Given this list of marker genes PLS1, CLDN11, KRTAP26-1, RPS16, THBS2, ARC, FMOD, COL9A1, TUBB2B, KRTAP24-1, TUBB6, CRYGS, MRPL43, KHDC3L, NEFH, COL4A4, H2AZ2, CTNNA1, RPL7, RPS3A, DPT, GPM6B, FBN3, TTN, KRTAP29-1, ENAM, LIM2, DCTN3, STATH, LMNTD2, RPS4Y1, HAPLN1 (hyaluronan and proteoglycan link protein 1, NCBI Gene Id 1404), H2AX (NCBI Gene Id 3014), H2AC18, LTBP4, ERBIN (NCBI Gene Id 55914), MACROH2A1, NUP160, SHANK1, COL8A1, FBLN1, H4C11, KRT222, H2BC9, HSPB2, RPS6, RPS7, THBS3, H2AC15, H1-2, RPLP1, COL4A1, CLDN19, ESM1, KRT16, DCN, AMELY, TUBB8B, LAMA1, H1-3, SEH1L, SEC13, RPS28, EPB41, CRYGC, RPL11, MRPS21, KRT17, NPNT, RPL7A, NUP155, H3C1, H3C8, TNC, RPL10L, EPB41L3 (erythrocyte membrane protein band 4.1 like 3), CRYGD, COL1A1, POTEE, KRT28, RPS3, H4C4, KRT79, KRT24, SEPTIN4, SMTN, MRPL20, SEC31B, BICD1, PXDN, EPB42, ELN, KRTAP25-1, CLTA, THBS1, COL6A5, OGN (NCBI Gene Id 4969), TFPI2, VWF, CLDN24, COL8A2, LAMA3, MACF1, KRTAP5-8, KRT13 (NCBI Gene Id 3860), MRPS23, KRT20, MRPL46, POTEI, H3C13, LTBP2, TUBA3C, COL2A1, H2BC19P (NCBI Gene Id 337874), NUP98, KRT71, RPS10, MRPS15, NUP205, PCOLCE, PANX2, HMCN2 (NCBI Gene Id 727754), NUP88, KRT81, KRTAP27-1, KRTAP3-3, LZTS1-AS1, MRPS22, KRT3, H3-7, ADIPOQ, MRPL42, YEATS4, ACTN2, VIM, COPG2 (COPI coat complex subunit gamma 2), SNTG2, MRPL51, TPM4, EDIL3, CAPN3, MFAP4, MRPL52, CLDN7, NID2, RPLP0P6, H2AB2, SPTAN1, TUBE1, RPS25, SNTG1, BGN, PSMD13, IMPG2, MMRN1, LAMA5, JPH1, COL17A1, H1-1 (H1.1 linker histone, cluster member), MYBPH, EPB41L2, NEB, KRT26, HMGA1, RPSA, POM121L2, MRPL15, KRTAP3-1, H3C10, H2BC15, KRT83, ARPC3, CRYBA1, APOE, LAMC1, MATN3, KRT6B (NCBI Gene Id 3893), ACTR3, PGM5, CSRP3, TMEM30A, CLDN6, CTHRC1, PANX3 (NCBI Gene Id 116337), DBNL, LAMB1 (laminin subunit beta 1), COPE, RPS23, HSPG2, NUP62CL, FBLN2, RPL9, SEPTIN7, SPTB, RPS2, LAMB3, MMRN2, MRPL36, COL6A6, MRPL30, COL4A2, DLG1, MAP7, MRPS30, NDUFAB1, SPTA1, MUC3A, RPL26L1, BFSP1, MXRA5, CLTC, COL3A1, KRT19, TNXB, H2AC19, H3C12, NUTF2, PCLO, RPS24, MRPS33, SEPTIN5, VCAN, CD2AP, COL11A2, CLDN10, H2BC14, KRT39, MRPS31, CRYGN, MRPL32, DSP, OBSCN, KRT32, CLDN34, CLDN15, KRT40, CRYBB1, KRT74, PSMD11, OPTC, RPLP0, RIMS3, ANK2, OLFM4, RPS27A, H1-10, TCAP (titin-cap), CD4, VPS25, ASPN, H3C14, EIF3A, SPRR1A, RPL41 (NCBI Gene Id 6171), RPSA2, H2AC20, MGP, MYBPC3, TECTA, KRT77, LTBP1, H1-0, RPS11, MAL, COPB1, POM121C, PDLIM3, MRPS5, FGA, CRYBA2, DMD, H3C6, MRPL35, COL1A2, TUBGCP4, H2AC13, CRYGB, POSTN, H3Y1, FBN1, GFAP, COL9A3, LAMA4 (NCBI Gene Id 3910), TUBA1B, ARPC2, BGLAP (bone gamma-carboxyglutamate protein), ANK1, MFGE8, RPL37, RPL3, DAP3, AMELX, RPL10, COL9A2, CLDN25, HIP1, POTEKP, COL5A1, RPL37A, ARPC4, COL12A1, KRT27, MRPS6, KRT23, MRPS9, TPM2, KRT12, RPS14, LAMC3, CRYBB3, KRT6C, RPL22L1, MAL2, TUBB3, COL27A1, RPS20 (ribosomal protein S20), TUBB, RPL38, CMTM8, FLG, RPS9, PLS3, NPAP1, RPL30, COL16A1, TUBB4B, KRT7, ERC2, KRT34, H3-5, MARVELD1, H2BC17, NUP133, H2AC7, MYL3, PPFIA2, AMBN, NUP93, H2AC16, MRPS35, RPL4 (ribosomal protein L4), KRT10, KRT15, MBP, H4C5, RSL24D1, JUP, MRPL16, SPTBN2, SPRR2E, RPS26, TLN1, TLE6, H2BC7 (H2B clustered histone 7), RAPSN, H3C2, MRPL34, CYLC2, VCL, RPL29, TGM3, RPL10A, NUMA1, ACAN, PI3 (NCBI Gene Id 5266), EMILIN3, TUBAL3, KRT76, MRPL10, KRT31, MYH11, NEFL, LORICRIN, RPL19, ERVK13-1, PNPLA1, MATN1, TLN2, LAMB2, MRPL1, NUP153, H2AP, IMPG1, COL24A1, CLTB, EFEMP2, H4C1 (H4 clustered histone 1), MRPL12, LUM, RPS12, SPTBN4, RPL37AP8, MRPL2, AHNAK, ANKRD2, MYL11, OOEP, RNA5S9, LMNA, ZP2, H2AC1, KRT18, CENPA, COL4A3, THSD4, SRBD1, RPL3L, KRT38, H3Y2, CRELD1, PLLP, RPL23, ERC1, POM121B, KRT85, KRT4, MRPL55, H2BC5, TUBA3E (tubulin alpha 3e), ATP5F1D, POTEJ, RPL39L, FN1, TUBA1A, H2BK1, KRT6A, MEPE, BVES, COL5A2, TUBA8, BSN, RPL12, PLP1, UPK1B, MRPL41, H2BC12, RPL13, ACTR2, H2AC4, KRT82, RPS27, MRPS16, SRPX, RPL34, MYH8, CILP, MYBPC2, ABI3BP, H1-8, MRPL18, RPS4X, HLA-DRB1, FLG2, ACTN3, SORBS3, MATN2, TPM1, ARPC1B, MYOM1, H2BC12L, SNTA1, ADD2, CLDN4, RNA5-8SN5, SBSPON, MRPS12, PRG2, UBA52, TUBG1, NDC1, DAG1, OC90, HMCN1, MRPS24, ACTB, MAP1B, H3-3A (NCBI Gene Id 3020), COL11A1, KRT78, EPB41L4B, B2M, PPL, ZP4, CSRP1, H1-5, SYNM (synemin), NUP62, CLDN1, H2BC21, H2BC1, ACTL6B, H3C7, ADD3, LAD1, RPL35A, MRPL27, KRTAP11-1 (NCBI Gene Id 337880), NPHP4, TUBA1C, PLEC, PANX1, NEFM, MYBPC1, MSN, CHI3L1, H4C15, RPL36, TPR, EFEMP1, NUP58, H2AB1, H2BC4, H4C9, RPL14, TUBG2 (NCBI Gene Id 27175), H2BC8, KRT33B, FBLN5, COL14A1, TECTB, SRPX2, RPS29, RPL5 (NCBI Gene Id 90045), KRT5, GNL1, H2BC13, H2AC6, KRT25, H2AC17, FGL2, NID1, RPS19, MRPL54, CLDN3, H3C15, MRPL21, SPOCK1, RPS27L, H2BN1, MRPL14, RPS18, COMP, RPL24, COL10A1, AEBP1, H2AC25, EPPK1, KRT14, INA, ZP3, FAU, MRPS7, MYL1, RPL26, CROCC, EMILIN2, RPL35, MYL6, SORBS2, KRT72, NPHP1, MACROH2A2, POTEF, MRPS18A, RPL27, H4C6, ACTL7B, KRTAP3-2, OTOL1, TUFT1, SPON1, KRTAP13-2, TUBA3D, KRT37, MAP4, COL6A1, TUBB1, ARPC5, MYOM2, COL23A1, CLDN14, MRPL9, SNTB1, TUBA4A, PRG4, RPL22, MRPL4, MRPS11, KRT80, H2BW1, H4C13, LAMC2, CLDN23, CTNNA2, RPL39, RPS15, SPTBN1, SEC31A, MRPL23, RPL8, RPS21, RPL18A (NCBI Gene Id 6142), MAP1A, H4C7, ASPH, MRPL28, CLDN20, EVPL, H3-3B, RNA5S1, H4C3, HSPB6, CLDN17, CRYGA, TINAGL1, MPZL1, CLTCL1, KRT33A, RPL21, BFSP2, CLDN18, RPS17, H2AC8, ACTN1, H2BC6, MALL, HMGCL, GIT1, DSPP, H3C3, ACTG1, MRPS18B, COL6A3, PODNL1, MRPS34, PKP1 (NCBI Gene Id 5317), SPRR3, MRPL49, MRPL22, MRPL3, LLGL1, RPL6, MRPL45, COL22A1, PRG3, KRT1, NUP107, H3C11, COL15A1, COL13A1, MYL9, FGB, H4C12, MRPS18C (NCBI Gene Id 51023), COL6A2, H2BW2, CCN1, RPS8, COPB2, H2BC11 (H2B clustered histone 11), JAG1, SNTB2, CSRP2, MRPS2, CHADL, PADI6, ACTBL2, CRYBB2 (crystallin beta B2), RPL13AP3, COPG1, DST, COLQ, MIP (NCBI Gene Id 4284), KRT73, NUP54, PODN, COPA, MFAP5, KRT9, H2AL3, NCMAP, CLDN8, ANOS1, NUP188, SPRR1B, TUBD1, KRTAP13-1, MRPL37, KRT2, CPOX, NLRP5, CLDN16, CLDN9, VTN, CCDC6, RIMS2, LMNB2, NUP214, COL18A1, RPS4Y2, ODF2, CLDN5, PRELP (NCBI Gene Id 5549), CRYBG3, H4C8 (NCBI Gene Id 8365), H1-6, H3C4, COL19A1, MRPS17, MRPL57, MRPL24, H2BC3 (H2B clustered histone 3), NUP35, RPL13A, KRT75, COL28A1, ACTL8, MYL6B, RPL23A, KRTAP16-1, KRT36, FGG, IGFBP7 (insulin like growth factor binding protein 7), KLHL3, RPLP2, EPB41L1, ROCK2, CYLC1, TGFBI, ANK3, KRTAP1-3, MYOT, RPL27A, NEXN, MPZ, MRPL33, LAMA2, MFAP2, KRT35, ZP1, H2BC10, POM121, H3-4, MRPS14, PRPH, RPL7L1, RPL32, RIMS1, FBN2, RPS5, RPS13, H2BC26 (NCBI Gene Id 128312), COL25A1 (NCBI Gene Id 84570), TUBA4B, SPAG4, ECM1, KRT84, COL21A1, AGRN, TUBB2A, MRPL17, CRYAA, MUC4, H2AZ1, MYL2, MUC6 (NCBI Gene Id 4588), COL5A3, HAPLN4, LYRM4, VILL, TUBB4A, H2AB3, MUC17, CLDN22 (NCBI Gene Id 53842), LMNB1, RPL15, H2BC18, COL4A5, RPS10P5, VWA1, RPL36A, STX2, CRYAB, RPL28, MATR3, RPS15A, KRT86, MAP2, CRYBA4, TUBGCP3, EMILIN1, H4C14, H4C16, RPL17, H2AC12, H2AJ, COL7A1, RPL36AL (NCBI Gene Id 93632), COL4A6, H1-4, MRPL13, MRPL11, DES, H2AC11, ACTL7A, HMOX1, H4C2, MOBP, NUP85, PNN, MRPL19, RPL18, TUBB8, NEBL, H2AC21, SPARC, RPL31 (NCBI Gene Id 6160), CLDN2, ACTA1, IGF1R, MUC5AC, INSR, RPL39P5 (ribosomal protein L39 pseudogene 5), MRPL47, MAPK8IP2, MRPS25, MYL5, here is a description of the gene set: Human Gene Set: GOMF_STRUCTURAL_MOLECULE_ACTIVITY studied in species Homo sapiens The action of a molecule that contributes to the structural integrity of a complex.